Given this list of marker genes COL28A1, RIC3, HGS, THBS1, MARCHF11, CHGB, CSRNP2, GPR4, TAF8, NRIP1, USP42, POGZ, SERTAD1, FAM114A2, ATXN7L2, PTPRU, AGFG1, VPS4B, PHF2, KRT2, TNIP1, RRP1B, HMX2, CCDC148, AVPR1A, ZFP57, CUX1, GPRIN2, GCK, CSTL1, ALKAL1, ESRP2, KRBA1, NANOS2 (nanos C2HC-type zinc finger 2), MIR19A, SH3TC2, PI15, KCNA6, PTK2B, AMIGO1 (NCBI Gene Id 57463), APBB1IP, SSTR2, NIPAL4, FILIP1, TBX6, JOSD2, SUGCT, GALNT18, CPQ, PRF1, N4BP2, GPC2, GCN1, MICAL2, ITGA6, NT5M, FASTKD1, GGCX, ANO3, ZBTB49, FEM1A, NELFA, GTF2I, IL6ST, HNRNPK, TTC38, ZSWIM4, NCOR2, PML, VPS39, STAT3, SF1, ADAM7, PNMA2, NRG3, ZFP30, USP12, TGFBR3, ZC3H12D (NCBI Gene Id 387078), ZFAND2A, BEGAIN, FAM168B, GTPBP4, CNN3, SLC6A3, NFATC3, TCF7 (NCBI Gene Id 6932), STMN4, KHDRBS3, BTG1, MYO15B, C14orf39, FRAT1, AXIN1, LRIG3, LEF1, PPP1R11, TCP11L2, ISM1 (isthmin 1), ACAN (aggrecan), MIR488, SMAD7, TOLLIP, CFAP100, SV2B, ISCU, SLC11A1, CNN1, CEP126, MATN2, NSA2, HS3ST5, PLCXD2, MAP3K3, SAP30BP, IGFBP1, UBC, OCLN, SAA2, MIR17, UTP4, ABLIM3, VDR, UBAP2 (NCBI Gene Id 57627), CMTR2, IL21R, DSP, ZNF394, SETD1B, NIPAL2, SLC13A2, KLF3, GEMIN5, PLBD2, MCTP2, TBX20, ITPKC (NCBI Gene Id 80271), PROM1, PRSS58 (NCBI Gene Id 408203), ZDHHC18, CTDNEP1, ZC3H12C, PCDHB7, COX8BP, GUCA2A, MIR376B (NCBI Gene Id 574435), TXNL4B, LSAMP, SLC30A9, DMRT1, SLC22A25, here is a description of the gene set: from publication Popov A, Driesen J, Abdullah Z, Wickenhauser C, Beyer M, Debey-Pascher S, Saric T, Kummer S, Takikawa O, Domann E, Chakraborty T, Krönke M, Utermöhlen O, Schultze JL (PMID 18802101) Genes up-regulated in dendritic cells: immature versus mature inhibitory treated by prostaglandin E2. Human Gene Set: GSE9946_IMMATURE_VS_PROSTAGLANDINE2_TREATED_MATURE_DC_UP Myeloid dendritic cells (DC) and macrophages play an important role in pathogen sensing and antimicrobial defense. Recently we demonstrated that infection of human DC with intracellular bacterium Listeria monocytogenes (L.monocytogenes) leads to the induction of the immunoinhibitory enzyme indoleamine 2,3-dioxygenase (Popov et al., J Clin Invest, 2006), while in the previous studies L.monocytogenes infection was associated with a rather stimulatory DC phenotype. To clarify this discrepancy we performed comparative microarray analysis of immature mo-DC (immDC), mature stimulatory mo-DC (matDC) and mature inhibitory DC either stimulated with prostaglandin E2 (PGE2-DC) or infected with L.monocytogenes (infDC). Studying infection of human myeloid DC with Listeria monocytogenes, we found out, that infected DC are modified by the pathogen to express multiple inhibitory molecules, including indoleamine 2,3-dioxygenase (IDO), cyclooxygenase-2, interleukin 10 and CD25, which acts on DC as IL-2 scavenger. All these inhibitory molecules, expressed on regulatory DC (DCreg), are strictly TNF-dependent and are in concert suppressing T-cell responses. Moreover, only DCreg can efficiently control the number of intracellular listeria, mostly by IDO-mediated mechanisms and by other factors, remaining to be identified. Analyzing publicly acessible data of transcriptional changes in DC and macrophages, infected by various pathogens and parasites (GEO, GSE360), we noticed that infection of these cells with Mycobacterium tuberculosis causes transcriptional response, comparable with the one caused by listeria in human DC. In fact, granuloma in tuberculosis and listeriosis in vivo are enriched for myeloid DC and macrophages characterized by regulatory phenotype. In summary, regulatory myeloid DC and macrophages may play a dual role during life-threatening granulomatous infections, such as tuberculosis: on one hand, regulatory myeloid cells promote pathogen containment by efficiently killing intracellular bacteria, on the other hand these cells inhibit granuloma-associated T cells and thereby might be involved in the retention of TNF-controlled granuloma integrity protecting the host from granuloma break-down and pathogen dissemination. studied in species Homo sapiens